The following is a description of a gene set: species: Homo sapiens 50 most interesting genes up-regulated in pancreatic cancer cell lines (AsPC1, Hs766T, MiaPaCa2, Panc1) but not in the non-neoplastic cells (HPDE) by TSA. To identify potential targets for aberrant methylation in pancreatic cancer, we analyzed global changes in gene expression profiles of four pancreatic cancer cell lines after treatment with the demethylating agent 5-aza-2'-deoxycytidine (5Aza-dC) and/or the histone deacetylase inhibitor trichostatin A. A substantial number of genes were induced 5-fold or greater by 5Aza-dC alone (631 transcripts), trichostatin A alone (1196 transcripts), and by treatment with both agents (857 transcripts). Four hundred and seventy-five genes were markedly (>5-fold) induced after 5Aza-dC treatment in pancreatic cancer cell lines but not in a nonneoplastic pancreatic epithelial cell line. The methylation status of 11 of these genes was examined in a panel of 42 pancreatic cancers, and all 11 of these genes were aberrantly methylated in pancreatic cancer but rarely, if any, methylated in 10 normal pancreatic ductal epithelia. These genes include UCHL1 (methylated in 100% of 42 pancreatic cancers), NPTX2 (98%), SARP2 (95%), CLDN5 (93%), reprimo (86%), LHX1 (76%), WNT7A (71%), FOXE1 (69%), TJP2 (64%), CDH3 (19%), and ST14 (10%). Three of these genes (NPTX2, SARP2, and CLDN5) were selected for further analysis in a larger panel of specimens, and aberrant methylation of at least one of these three genes was detectable in 100% of 43 primary pancreatic cancers and in 18 of 24 (75%) pancreatic juice samples obtained from patients with pancreatic cancer. Thus, a substantial number of genes are induced by 5Aza-dC treatment of pancreatic cancer cells, and many of them may represent novel targets for aberrant methylation in pancreatic carcinoma. Human Gene Set: SATO_SILENCED_BY_DEACETYLATION_IN_PANCREATIC_CANCER from publication Sato N, Fukushima N, Maitra A, Matsubayashi H, Yeo CJ, Cameron JL, Hruban RH, Goggins M (PMID 12839967), and this is the list of marker genes: MAGED4B, EGR4, BIK, CGREF1, TFPI2, ADM, PER1, CHFR, ID2, STC1, UCP2, FOXN3, CACNA1G, GDF15 (NCBI Gene Id 9518), SERPINI1, AREG, HPSE, CAPN5, SSX1, KLK12, NPRL2, CDH8, CLDN15, NOTCH3 (notch receptor 3), CXCL8, GAGE12G, NGFR, GAGE12F (NCBI Gene Id 389855), MBD1, GAGE1, WNT4, ABCB1, PHC1, H1-2, ING1, CDKN1C, DHRS2, ULBP2, GADD45B, HMOX1, SPANXA1, MMP1, ATF3, EREG, CCN2, ANGPT1, HBA1